The following is a description of a gene set: Human Gene Set: MIR6508_3P from publication Chen Y, Wang X (PMID 31504780) species: Homo sapiens Genes predicted to be targets of miRBase v22 microRNA hsa-miR-6508-3p in miRDB v6.0 with MirTarget v4 prediction scores > 80 (high confidence targets)., and this is the list of marker genes: SMAD9, RNF44, CA14, WDFY3, CD300C, CBX7, SARDH, PIGF, SENP1, AR, NBR1, RELN, ZKSCAN8 (zinc finger with KRAB and SCAN domains 8), MAP3K19, SNX27, TMIE, CCDC71L, LARGE1, TNIK, NOMO1, PLEKHA5, CLDN1, ME3, PHYHIP, NOMO2, TLN2, SLC8A1, ZNF106, DENND5A, FOXL2NB, TMEM178B, PSD3, PARS2, VAPA, SFPQ, TGM2, ZNF592, SERPINA5 (serpin family A member 5), NOMO3, HEPACAM, EPDR1, CTNNA2, ZNF202, CD53, KIF18A, TUBGCP4, TXLNA, TAFA1, CFAP20